The following is a description of a gene set: Genes predicted to be targets of miRBase v22 microRNA mmu_miR_298_3p in miRDB v6.0 with MirTarget v4 prediction scores > 80 (high confidence targets). Mouse Gene Set: MIR_298_3P from publication Chen Y, Wang X (PMID 31504780) species: Mus musculus, and this is the list of marker genes: Zfp644 (zinc finger protein 644), Lats2, Slc23a2, Gje1, Map3k8, Ptar1, Sppl2a, Ccdc71l, Pou2f1, Fam199x, Fgd6, Nvl, Dynlt1f (dynein light chain Tctex-type 1F), Gng10 (guanine nucleotide binding protein (G protein), gamma 10), Slc22a15, Ptrhd1, Gabra4, Ripor2, Krt26, Iyd, Klf4, Primpol, Krtap4-13, Sphk1, Braf, Lipo2 (lipase, member O2), Cd180, Zeb1, Cacul1, Txlnb, Marchf6, Ap4s1, Ckap5, Nectin1, Cpeb4, Rab23, Mcc, Dnajb2, H2bc21, Bmp3, Krtap4-20, Mier3, Chm, Ikzf5, Pcsk5, Hnrnpk, Mylk, Cul3, Dynlt1a, Atad2, Hadhb, Larp4, Ube2q2, Nkx2-1, Rora, Antxr1, Trpc5, Cnp, Nufip2, Appl2, Sec23a, Zbtb41, Rtn1, Sec23ip, Coq9, Plce1, Ppp3r2, Krtap4-21, Thumpd3